The following is a description of a gene set: Reactome Pathway: Apoptotic cleavage of cell adhesion  proteins part of: Apoptotic cleavage of cellular proteins This event has been computationally inferred from an event that has been demonstrated in another species.<p>The inference is based on the homology mapping from PANTHER. Briefly, reactions for which all involved PhysicalEntities (in input, output and catalyst) have a mapped orthologue/paralogue (for complexes at least 75% of components must have a mapping) are inferred to the other species. electronically inferred by orthology from the curated human pathway species: Mus musculus, and this is the list of marker genes: Ctnnb1, Ocln, Cdh1, Dsg1a, Dsg3, Casp3